The following is a description of a gene set: Eicosanoid lipid synthesis map Mouse Gene Set: WP_EICOSANOID_LIPID_SYNTHESIS_MAP species: Mus musculus, and this is the list of marker genes: Ptges, Ptgds, Pgs1, Pla2g4b, Pla2g5, Pla2g4a, Pla2g6, Alox5, Ptgs2